The following is a description of a gene set: from publication López-Ríos F, Chuai S, Flores R, Shimizu S, Ohno T, Wakahara K, Illei PB, Hussain S, Krug L, Zakowski MF, Rusch V, Olshen AB, Ladanyi M (PMID 16540645) Most gene expression profiling studies of mesothelioma have been based on relatively small sample numbers, limiting their statistical power. We did Affymetrix U133A microarray analysis on 99 pleural mesotheliomas, in which multivariate analysis showed advanced-stage, sarcomatous histology and P16/CDKN2A homozygous deletion to be significant independent adverse prognostic factors. Comparison of the expression profiles of epithelioid versus sarcomatous mesotheliomas identified many genes significantly overexpressed among the former, including previously unrecognized ones, such as uroplakins and kallikrein 11, both confirmed by immunohistochemistry. Examination of the gene expression correlates of survival showed that more aggressive mesotheliomas expressed higher levels of Aurora kinases A and B and functionally related genes involved in mitosis and cell cycle control. Independent confirmation of the negative effect of Aurora kinase B was obtained by immunohistochemistry in a separate patient cohort. A role for Aurora kinases in the aggressive behavior of mesotheliomas is of potential clinical interest because of the recent development of small-molecule inhibitors. We then used our data to develop microarray-based predictors of 1 year survival; these achieved a maximal accuracy of 68% in cross-validation. However, this was inferior to prognostic prediction based on standard clinicopathologic variables and P16/CDNK2A status (accuracy, 73%), and adding the microarray model to the latter did not improve overall accuracy. Finally, we evaluated three recently published microarray-based outcome prediction models, but their accuracies ranged from 63% to 67%, consistently lower than reported. Gene expression profiling of mesotheliomas is an important discovery tool, but its power in clinical prognostication has been overestimated. Human Gene Set: LOPEZ_MESOTHELIOMA_SURVIVAL_OVERALL_DN Top genes associated with unfavorable overall survival of mesothelioma patients after surgery. species: Homo sapiens, and this is the list of marker genes: FLNB, PSRC1, HOXB6, MBOAT2, DLGAP4, TUBB2A, PLXNA3, TGFB1I1, CCND1 (cyclin D1), JPT1, PIMREG, CD24, COL5A1, NEK2, STC2